Given this list of marker genes Eps8, Slamf1, Mest (mesoderm specific transcript), Ndrg2 (NCBI Gene Id 29811), Slc6a20a, Alox5, Fam174b, Car8, Serpinb2, Apoe, Cpne7 (copine VII), Nrip3, Zfp185, Phlda2, Cpne5, Hmgcs2, Nudt11, Gda, Cda, Fmo1, here is a description of the gene set: studied in species Mus musculus Top 20 up-regulated genes in leukemic progenitor cells expressing activated fusion of ESWR1 and FLI1 compared to normal hematopoetic progenitors. Mouse Gene Set: TORCHIA_TARGETS_OF_EWSR1_FLI1_FUSION_TOP20_UP from publication Torchia EC, Boyd K, Rehg JE, Qu C, Baker SJ (PMID 17875932) EWS/FLI-1 is a chimeric oncogene generated by chromosomal translocation in Ewing tumors, a family of poorly differentiated pediatric tumors arising predominantly in bone but also in soft tissue. The fusion gene combines sequences encoding a strong transactivating domain from the EWS protein with the DNA binding domain of FLI-1, an ETS transcription factor. A related fusion, TLS/ERG, has been found in myeloid leukemia. To determine EWS/FLI-1 function in vivo, we engineered mice with Cre-inducible expression of EWS/FLI-1 from the ubiquitous Rosa26 locus. When crossed with Mx1-cre mice, Cre-mediated activation of EWS/FLI-1 resulted in the rapid development of myeloid/erythroid leukemia characterized by expansion of primitive mononuclear cells causing hepatomegaly, splenomegaly, severe anemia, and death. The disease could be transplanted serially into naïve recipients. Gene expression profiles of primary and transplanted animals were highly similar, suggesting that activation of EWS/FLI-1 was the primary event leading to disease in this model. The Cre-inducible EWS/FLI-1 mouse provides a novel model system to study the contribution of this oncogene to malignant disease in vivo.